The following is a description of a gene set: studied in species Homo sapiens Human Gene Set: GOBP_MRNA_METABOLIC_PROCESS The chemical reactions and pathways involving mRNA, messenger RNA, which is responsible for carrying the coded genetic 'message', transcribed from DNA, to sites of protein assembly at the ribosomes., and this is the list of marker genes: ACIN1, FAM76B, HBS1L, MIR96, DCP1A, KHSRP, DNAJC17, RSRC1, MIR20B (NCBI Gene Id 574032), SF3B3, LSM14B, CTNNBL1, PUM1, PPIE, TRA2B, HNRNPK, MIR206, ZCCHC7, TAF4B, MIR93, SLU7, ZAR1, PAF1, SNRPN, CTIF, RNU5B-1, BTG2, YTHDF2, PCIF1 (NCBI Gene Id 63935), PCBP2, TRAF5, RNASEL, RNVU1-19, BUD13, MEIOC, MFAP1, E2F1, REST (RE1 silencing transcription factor), RNVU1-15, MIR424, RBM46, PUS7L, AQR, LSM5, ARVCF, DXO, CSTF3, MIR195, MTREX, FRA10AC1, SFPQ, PRPF19, AKAP8L, PABPC4, YJU2B, PRMT5, MIR128-1, PABPN1, ADARB1, RBM42, RNVU1-1, DYRK1A, HNRNPU, CWC27, RBMY1F, MRTO4, MIR27B, MIR608, NANOS3 (NCBI Gene Id 342977), WBP11, FMR1, BUD31, FTO, DDX1, MIR100, CDK11B, MIR4286, AHCYL1, PHF5A, MIR320A, SETX, PRPF38A, FASTKD3, MIR1-1, EXOSC4, RBM15, MIR200C, MIR192, PPIL1, RARA, NPM1, RNU5F-1, IGF2BP2, TAF8, PAN3, RNU1-4, EDC4, GTPBP2, RBM6, IGF2BP1, MIR24-1, RPRD1B, BOLL, ZMAT5 (NCBI Gene Id 55954), DAZ1, MIRLET7C, LUC7L3, IRF3, SND1, NBDY, KHDC4, WDR33, PAXBP1 (NCBI Gene Id 94104), MTPAP, ESRP2, SNRPF, TTC5, SRRM2, COIL, FLNA, THOC1, ZNF473, HNRNPAB, CBLL1, MIR145, CWC25, TNRC6A, MYOD1, LSM8, CACNG7, ROCK1, MIR29B1, TENT5A, APLP1, RBM4, RBFOX3, TAF9, DDX23, TAF11, CNOT4, MIR708, SKIC2, WDR77, PUM2, BCAS2, PABPC1, PLRG1, FUS, PQBP1, SF3A2, SAMD4B, EXOSC10, SCAF11, PABPC3, FASTKD5, SYNCRIP, PPP1R8, FOXE3, HNRNPH3, GCFC2, CLNS1A, SSU72, RNH1, ALYREF, TAF12, CPEB1, DND1, SNRPA, MBNL1, NT5C3B, THOC2, GEMIN7 (NCBI Gene Id 79760), DCPS, RBBP6, FRG1, RXRB, CASC3, CLASRP, MIR223, TP53, MBNL2, CELF4, CWF19L1, HSF1, GSPT2, CCAR2, RBMXL1, ZFP36L1, NCBP2L, EIF4ENIF1, CALCR, RBM41, RSRP1, MIR326, BRDT, SSU72L6, METTL14, TUT1, MIR373, PRKACA, SMG1, HOXB-AS3, MIR517A, WDR83 (NCBI Gene Id 84292), SNRPD2, ZFP36L2, VDR, SYF2, ZC3H12A, ZC3H12D, RBM7, PAIP1, U2AF2, ZCRB1, EXOSC3, TRMT61A (NCBI Gene Id 414769), PATL2, SCAF1, CMTR1, RBMXL2, PRPF38B, RNVU1-3, TUT4, SNRPD3, MIR19A, DUS3L, SNRPE, NANOS1, WBP4, CPSF2, TENT5C, TAF10, BARD1, SNRPG, RBM25, PUF60, PRP4K, PNRC2, MEX3D, THRB, RBMY1A1, SSU72L1, RNVU1-14, MIR151A, PIAS4, ZC3H3, HNRNPL, RBM3, DDX17, AGO4, SRSF11, APOBEC2, JMJD6, SRSF5, ETF1, NFKBIZ, SSU72L5, HNRNPA0, TNRC6B, LEO1, TFIP11, MAPKAPK2, RBM28, LSM10, THOC6, DHX40, SNU13, HNRNPLL, MIR342, MIR302C, TRUB2, EREG, HNRNPR, MIRLET7A1, NUDT21, LSM2, METTL3, SRSF4, MIR517C, DBR1, TSEN54, HNRNPC, RIDA, RNPS1, RNU4ATAC, PPIL3, NCOA2, MIR20A, SRRM1, SUPT6H, IREB2, RBM23, A1CF, CNOT6L, RNVU1-17, TAF1, ZRANB2, DDX41, PNPT1, RBM48, NCBP2, MIR302A, SRRM4, SF3B5, MIR27A, TRMT2A, AGO3, CPSF6, GEMIN2 (NCBI Gene Id 8487), IKBKE, DIS3L2, DCP2, CNOT2, CAPRIN1, ILF3, HNRNPD, PKP3, AKT1, MIR519A1, FBXO24, GRSF1, SF3A3, WTAP, RAMAC, RNU5E-1, CACTIN, TAF13, KIN, EXOSC8, CEBPG, RNU6-7, CDC5L (NCBI Gene Id 988), CSDE1, VIRMA, GPATCH1, CWC22, KAT8, MIR142, CPSF1, CENATAC, MIR137, NSRP1, PPIL2, DHX34, PKP1, USP49, ERN1, HNRNPUL2, MIR30B, SKIC3, KHDRBS1, SSU72L4, MIR212, DCP1B, U2AF1L4, TAF2, MIR211, THRAP3 (NCBI Gene Id 9967), SERBP1, MIR486-1, GPATCH8, CSTF1, MIR146A, SNRPD1, SNRPB2, SCGB1A1, RALY, ARB2A, PNLDC1, SRSF10, MAPK14, ISY1, CDK11A, MIR483, MIR181C, ARID5A, THOC7, RPRD2, RNU11, MIR135B, SNRNP40, PCF11, CELF6, GTSF1, MBNL3, MYD88, EPAS1, PRR5L, MIR329-1, RBM38, SMG7, ARMC7, PATL1, MIR663A, DDX42, RBPMS, MIR519D, HNRNPM, MIR125B1, HSPA8, FBLL1, MIR9-1, RNU4-1, MIR106B, RNVU1-7, NUDT16L1, CWC15, CELF5, DIS3L, MIR181B1, PRPF31, CNOT6, IWS1, THUMPD2, GTPBP1, RBFOX1, MIR885 (NCBI Gene Id 100126334), TGS1, PARN, YBX1, RBM15B, PTBP1, SF3B4, ZBTB1, CDK13 (NCBI Gene Id 8621), DHX8, MIR34B, RBM33, MIR495, MIR543, PRKCD, ROCK2, PRPF40B, USP4, RPRD1A, CSTF2T, RBM44, MIR140, MIR103B1, RBFOX2, PRPF6, TAF5, ESRP1, MOV10, MIR497, RBMX2, SAMD4A, ATM, NCOA1, TAF4, TOB1, PUS7, PRPF39, LUC7L, CNOT1, SNRNP35, TAF12-DT, MIR106A, HABP4, AICDA, HNRNPA1L3, TXNL4A, RBM14, VIM, SRSF3, ANXA2, TRIM71, RRP1B, ATF2, SRSF7, HNRNPA1 (heterogeneous nuclear ribonucleoprotein A1), ALKBH5, LSM1, ERN2, ZHX2, SRPK2 (NCBI Gene Id 6733), HNRNPA3, CD2BP2, PUS1, SF3B2, RNU6ATAC, RNF113A, CNOT11, PCBP4, ATF4, MIR190B, DHX15, MIR133A1, NOCT, DDX39A, PAPOLB, ADAR, PPIH, NOVA2, SENP1, CNOT8, DAZL, TRAF3IP2, RNU5D-1, HNRNPH1, EXOSC6, PRKRIP1, EXOSC2, SF1, ANGEL2, NONO (non-POU domain containing octamer binding), PIWIL1, GEMIN5, LARP1B, DHX36, CPSF3, DAZ4, NORAD, RNU4-2, POLR2G, SF3B1, AFF2, QKI, RBM4B, SLTM, SUPV3L1, YTHDF1, MED1, CIR1, ZMAT2, LSM11, MIR130B, SMG9, NBAS, SECISBP2, RNGTT, DKC1, MIR185, NUDT12, MIR125A, MIR544A, MIR423, APEX1, EXOSC9 (NCBI Gene Id 5393), CIRBP, AAR2, MIR625, LGALS3, MYG1, FAM50A, TRMT61B, RBMX, MIR18A, ZNF326, TENT4A, RBM8A (RNA binding motif protein 8A), FASTK, SRSF12, ESS2, PRMT9, INTS15, HNRNPF, MIR181D, EIF4A3, RBMY1B, ECD, GEMIN4 (gem nuclear organelle associated protein 4), SREK1IP1, TARDBP, RNPC3, ARL6IP4, DNAJB11, DAZ3, AGO2, TESK1, PRPF4, CMTR2, UPF2, DHX38, SCNM1, HSPA1B, TENT5B, TBP, USP39, ZCCHC8, MIR210, TNRC6C, UBL5, YTHDC1, STRAP, LSM4, PTBP3, SMN2, YJU2, WEE2-AS1, CDK9, PRMT7, EXOSC7, THRA, SUGP1, PYM1 (NCBI Gene Id 84305), NSUN2, SRSF8, TAF3, THOC3, CSTF2, MLH1, NUDT16, C5AR1, MIR200B, SNRNP27, GEMIN8, S100A10, CDC73, PPP4R2, CLP1, HLTF, HNRNPA2B1 (heterogeneous nuclear ribonucleoprotein A2/B1), CDK12 (NCBI Gene Id 51755), TSSC4, MIRLET7B, ZNF830, TSEN2, METTL8, SMNDC1, SAP18, FASTKD2, NCBP1, ZPR1, SNRNP25, SF3B6, CELF3, ZFP36, SNRNP200, C9orf78, ZC3H14, SLC11A1, FXR2, CNOT7, SFSWAP, C1QBP, MIR214, PAPOLG, GDNF, TAF7, SNRPA1, LSM3, RC3H2, XRN2, SAFB, SUGP2, MIR130A, SMG8, KHDRBS2, CELF1, KHDRBS3, PNRC1, RNVU1-8, MIR520C, ZIC3, SLFN14, SMN1, LARP4B, HDAC7, PAN2, SNRNP70, MIR19B1, ZRSR2P1, EFTUD2, RBM22, ELAVL4, GEMIN6, SNRPGP15, SF3A1, CPSF4, CARHSP1, MIR98, MIRLET7E, CELF2, RNMT, MIR491, CREB1, SRSF2, UPF3A, SLBP, TRA2A, RNVU1-4, TAF6, TIRAP, NICOL1, RNU6-1, SNIP1, RBMY1D, NANOS2, CNOT3, DDX39B, PRPF8, RNU5A-1, MIR564, RNU6-9, IK, NR1H3, PSIP1, SRSF6, SNW1, SNRPB, PDE12, CNOT10, STH, SNRNP48 (small nuclear ribonucleoprotein U11/U12 subunit 48), MBLAC1, CDC40, SRPK3, GIGYF2, H2AB1, ADARB2, RBMXL3, DHX35, ERI1, LARP7, XAB2, PRKCA, MIR26B, U2AF1, PTCD2, PIWIL2, LUC7L2, RBMY1J, UPF1, TRUB1, RC3H1, NCBP3, TTF2, PPARG, NUP98, CPEB3, NCL, ARGLU1, CRIPT, GSPT1, SSB, MIR665, CCNB1, MIR203A, MIR337, FASTKD1, APOBEC4, SNRPC, AKAP17A, EIF3E, TENT5D, IVNS1ABP, CSDC2, PNN, ATXN2L, SAFB2, AP3B1, RPUSD3, EDC3, MIR181A2, TBRG4, PRDX6, TNKS1BP1, UPF3B, PAPOLA, SREBF1, MIR340, MIR655, RPUSD4, SRSF1, HIPK3, RBPMS2, BAG4, DIS3, DAZAP1, LSM6 (LSM6 homolog, U6 small nuclear RNA and mRNA degradation associated), H2AB2, RBM39, APOBEC1, TSEN15, RNVU1-6, NOVA1 (NCBI Gene Id 4857), ZC3HAV1, HTATSF1, PRPF18, TCERG1, STAT3, RBMY1E (NCBI Gene Id 378950), SMG6, MIR193A, TENT4B, ELAVL1, TRAF2, NR1H2, PTBP2, LARP1, RBM20, METTL16, VIP, TENT2, YBX3 (Y-box binding protein 3), SON, SSU72L3, PABPN1L, TUT7 (terminal uridylyl transferase 7), AGO1, MIR191, RBM5, CWF19L2, CHD8, MIR562, TAF15, CPSF7, PPARGC1A, SYMPK, SMG5, SREK1, RNU2-1 (RNA, U2 small nuclear 1), AXIN2, SMU1 (NCBI Gene Id 731253), DHX16, DDX20, SDE2 (NCBI Gene Id 163859), SRPK1, RBM24, IGF2BP3, DDX46, HMX2, MIR485, MIR365A, MIR199B, TXNL4B, RPUSD2, TRMT6, MIR204, SART1, XRN1, RBM10, SLC39A5, TRMT10C, MAGOHB, LSM7 (NCBI Gene Id 51690), EXOSC5 (exosome component 5), NRDE2, NOL3, DHX9, H2AB3, MIR149 (microRNA 149), HNRNPUL1, RXRA, ZC3H13, MAGOH, FXR1, HSPA1A, RBM47, HNRNPA1L2, PCBP3, PELO, PRPF3, SRSF9 (NCBI Gene Id 8683), SART3, TSEN34, PLEKHN1, PPWD1, FIP1L1 (NCBI Gene Id 81608), ZRSR2, DDX5, MIR23A, TFCP2 (NCBI Gene Id 7024), PRPF40A, SKIC8, SSU72L2, GPKOW, PUS3, THOC5, YTHDF3, DAZ2, CRNKL1, RBM11, MIR501, CNOT9, DDX47, RNVU1-2A, RBM17, TIA1, ZBTB7A